Given this list of marker genes MIR29B1, FZD9, BLOC1S2 (biogenesis of lysosomal organelles complex 1 subunit 2), GSK3B, BCL2L1, ACAA2, EYA2, SLC25A5, MPV17L, ZNF205, BID, SIVA1, TP53, LRRK2, BAK1, PPIF, MIR29A, BOK (NCBI Gene Id 84558), RHOT2, ATF2, ATP5IF1, TMEM14A, RTL10, BNIP3 (NCBI Gene Id 664), MUL1, IER3, GCLC, MIR29C, BNIP3L, SLC25A4, SLC9A1, SPG7, RHOT1, HIP1R, HSPA1A, VDAC2, GSK3A, STPG1, SLC25A6, SLC25A31, TMEM102, BAX, CHCHD10, BCL2L11, SLC35F6, here is a description of the gene set: Human Gene Set: GOBP_POSITIVE_REGULATION_OF_MITOCHONDRIAL_MEMBRANE_PERMEABILITY studied in species Homo sapiens Any process that increases the frequency, rate or extent of the passage or uptake of molecules by the mitochondrial membrane.